Given this list of marker genes CLCN7, CSF1R, ABCC9, PSAP, PLEKHM1, ANKH, GBA1, SCARB2, TCIRG1, here is a description of the gene set: Human Gene Set: HP_ERLENMEYER_FLASK_DEFORMITY_OF_THE_FEMURS Erlenmeyer flask deformity of the femurs Flaring of distal femur. species: Homo sapiens